The following is a description of a gene set: Human Gene Set: GOBP_RESPONSE_TO_ACIDIC_PH studied in species Homo sapiens Any process that results in a change in state or activity of a cell or an organism (in terms of movement, secretion, enzyme production, gene expression, etc.) as a result of a pH stimulus with pH < 7. pH is a measure of the acidity or basicity of an aqueous solution., and this is the list of marker genes: RAB11B, KCNK4, CTSS, TRPV1, KCNK1, SST, ASIC1, RAB11FIP5, SCNN1D, GPR65, KCNK9, SCNN1A, GPR4, SCNN1B, GPR68, GPR151, KCNK3, GPR31, PKD2L1, SERPINF1, CHP1, ASIC3, SCNN1G, LGMN, PKD1L3, SLC9A1, ASIC2